The following is a description of a gene set: studied in species Homo sapiens The anaerobic enzymatic chemical reactions and pathways resulting in the breakdown of glucose to lactate, and possibly ethanol, yielding energy in the form of adenosine triphosphate (ATP). Human Gene Set: GOBP_GLUCOSE_CATABOLIC_PROCESS_TO_LACTATE, and this is the list of marker genes: ACTN3, TP53, LDHA, TIGAR, MIR210